The following is a description of a gene set: Mouse Gene Set: GOBP_ACTIVATION_OF_MEIOSIS species: Mus musculus Any process that starts the inactive process of meiosis., and this is the list of marker genes: Msx2, Meiosin, Camk2b, Npr2, Plcb1, Msx1, Stra8